Given this list of marker genes GUCY2C, SLC2A5, TREH, CHIA, CEL, SI, AMY1A, PNLIPRP3, PIR, RSC1A1, AMY2A, LCT, PNLIPRP1, MGAM, CLPS, ALPI, AMY1C, GUCA2B, PNLIPRP2, SLC2A2, PNLIP, AMY2B, LIPF, CHIT1, AMY1B (amylase alpha 1B), GUCA2A, NPC1L1, SLC5A1, here is a description of the gene set: Reactome Pathway: Digestion and absorption species: Homo sapiens Fats, carbohydrates, and proteins are broken down to small molecules - fatty acids, cholesterol, and glycerol, monosaccharides, and amino acids - within the lumen of the gastrointestinal tract and absorbed into the body principally through enterocytes in the small intestine. Some of the hydrolases that catalyze these reactions are secreted into the gastrointestinal tract; others are associated with the luminal surfaces of enterocytes. Movement of the final products of digestion out of the intestinal lumen is mediated by arrays of transporters associated with the lumenal and basolateral surfaces of enterocytes.